The following is a description of a gene set: Human Gene Set: GOMF_SPHINGOLIPID_TRANSFER_ACTIVITY studied in species Homo sapiens Removes a sphingolipid from a membrane or a monolayer lipid particle, transports it through the aqueous phase while protected in a hydrophobic pocket, and brings it to an acceptor membrane or lipid particle., and this is the list of marker genes: MTTP, PLEKHA8, PLTP, CPTP, GLTPD2 (NCBI Gene Id 388323), CERT1, TMEM63B, GLTP, PITPNB (NCBI Gene Id 23760), PLEKHA8P1